Given this list of marker genes PSMA6, PSMD1, PSMC4, PSMB6 (proteasome 20S subunit beta 6), UBB, PSMC5, PSMD11, PSMC1, PSMC3, PSMB4, PSMD2 (proteasome 26S subunit ubiquitin receptor, non-ATPase 2), PSMD7, PSMD3, PSMA1, UBA52, PSMD6, SEM1, PSMA4, PSMC6, PSMB1, PSMB3, PSMD13, PSMD8 (NCBI Gene Id 5714), PSMA2, UBC, PSMC2, PSMB5, ADRM1, PSMB7, PAK2, PSMB2 (NCBI Gene Id 5690), PSMA3, RPS27A, PSMD14, PSMD12, PSMA7, PSMA5, here is a description of the gene set: Stimulation of cell death by PAK-2 requires the generation and stabilization of the caspase-activated form, PAK-2p34. Levels of proteolytically activated PAK-2p34 protein are controlled by ubiquitin-mediated proteolysis. PAK-2p34 but not full-length PAK-2 is degraded by the 26 S proteasome. It is not known whether ubiquitination and degradation of PAK-2p34 occurs in the cytoplasm or in the nucleus. Reactome Pathway: Regulation of activated PAK-2p34 by proteasome mediated degradation part of: Regulation of Apoptosis studied in species Homo sapiens